Given this list of marker genes Chp1, Atp1b1, Drd4, Fgf13, Ank3, Tesc, Wnk2, Scn1b, Dmd, Cnksr3 (NCBI Gene Id 215748), Wnk3, Plcb1, Tescl, Slc9a1, here is a description of the gene set: studied in species Mus musculus Mouse Gene Set: GOBP_POSITIVE_REGULATION_OF_SODIUM_ION_TRANSMEMBRANE_TRANSPORTER_ACTIVITY Any process that activates or increases the frequency, rate or extent of sodium ion transmembrane transporter activity.